Given this list of marker genes Mtor, Hap1, Fbxo45, Nedd4, Ncs1, Pin1rt1, Hnrnpa2b1, Camk2d, Gnaq, Senp7, Sumo1, Prkcd, Pias3, Pin1, Homer1, Eif4ebp1, Htt, Eif4e, Syt1, Baiap2, Plcb1, Ube3a, Sumo2, Fus, Pten, Tnk2, Ogt, Ube2i, Dbn1, Kif5b, Kif5c (NCBI Gene Id 16574), Dag1, Pias1, Hspa8, Senp1, Aldoc, Rims3, Senp6 (NCBI Gene Id 74825), Sumo3, Calb1, Fabp5, Prkcg, Senp5, Kif5a, Plcb3, Fmr1, Camk2a, here is a description of the gene set: species: Mus musculus Mouse Gene Set: GOCC_POSTSYNAPTIC_CYTOSOL The region of the cytosol consisting of all cytosol that is part of the postsynapse.